Given this list of marker genes SKA2, LAT, SGO1, LINC02393 (long intergenic non-protein coding RNA 2393), IL9R, NR1I2, GUCA2B, SLC29A4, NFATC1, ATP5PB, CR2, TMEM231 (NCBI Gene Id 79583), CLHC1, VAX2, PAMR1, EI24, SLC2A2, ATP2A1, LRRC8C (NCBI Gene Id 84230), GAS7, LANCL3, MUC13, GP1BA, ATP1A3, ARAP2, KRT7, MSI1, DSPP, HOXA9, PRELID3A, TRIB1, NDUFAF6, THSD7A, RUNX2, GLS2, DNAJB13, SETD1B, NSD3, IL17RE, LIMK1, SNX18, MAP3K21, CYLC1 (NCBI Gene Id 1538), PDC, RAG2, GRAP, TNFRSF12A, IFNAR2, CTSZ, CASP7, FAM209A, MAD2L1, TBC1D32, SYNPO2L, BMP10, PANX3, SCLT1, CCDC157, MGAT4B, SLC10A6, TCHH, PRIM2, RABGGTA, WNT10A, MSANTD3, CPXM1, GLRA1, NPPC, ARHGEF39, RGS13, SPEN-AS1, LY96, LMO2, CFAP36, IGF2BP1, TMEM169, CEACAM20, MMP3, SHBG, ZNF784, ZNF334, KLHL32, SUCNR1, GNG8, CFAP43, TSNAXIP1, DPYSL3, P2RY10, MUC1, CENPS, TMEM138, PAK3, VEGFC, XBP1, SCNN1A, KRT8, HCN1, CEP89, ACER2, GYG1, SH2D1A, MZF1, KCNK12, DNMT3L, POM121, SUB1, TM6SF1, SFRP1, C16orf89, SLC2A3, CSTB, PLSCR4, CORO2B, LGALS12, TRPM2, TACSTD2, HBZ, KIAA0319, SIAE, SYNE3, CD28, ASB1, TSSK3, PPP6R2, NOSTRIN, GIPC2, CLIP4, APOA2, IL17RA, TTLL1, USP2, BBS5, TEX2, ERICH2, ICOS, SORT1, MCL1, CHRNA7 (cholinergic receptor nicotinic alpha 7 subunit), MAP9, GSTK1, PIP4P2, SP7 (Sp7 transcription factor), GSX2, TEAD3, RPL3, ROR2, CAMK2A (NCBI Gene Id 815), SLC6A18, CENPW, ARAP3, PGK2, MAOB, B3GALT5, FXYD5, TMCC3, CA13, RGS2, TECRL, HABP4, AUNIP, KLF3, NAPB, GALNS, C11orf24, NNAT, TMEM17, OR2C1, PITX2, PTPRE, IRF2BPL, LRRC56, NEGR1, SOHLH1, TRPC1, H1-0, DRP2, NR2C1, BMP2K, B3GNT5, TLR6, TGFB3, MAN1A1, PRKX, C18orf54, HECW2, GATA3, ARL10, ZNF608, CELA1, CENPB (centromere protein B), MYPOP, MYOZ2, PDE2A, DNAJB8, TLX3, MALL, ADCY1 (adenylate cyclase 1), CPEB4, GALNT6, FMO3, here is a description of the gene set: Human Gene Set: GSE24210_IL35_TREATED_VS_RESTING_TREG_UP species: Homo sapiens Genes up-regulated in T conv cells treated with IL35 versus resting T reg cells. Regulatory T cells (Tregs) play a critical role in the maintenance of immunological self-tolerance. Naïve human or murine T cell treatment with the inhibitory cytokine IL35 induces a regulatory population, termed iTR35, that mediates suppression via IL35, but not IL10 or TGFβ, neither express nor require Foxp3, are strongly suppressive in five in vivo models, and exhibit in vivo stability. Treg-mediated suppression induces iTR35 generation in an IL35- and IL10-dependent manner in vitro, and in inflammatory conditions in vivo in Trichuris-infected intestines and within the tumor microenvironment, where they appear to contribute to the regulatory milieu. iTR35 may constitute a key mediator of infectious tolerance and may contribute to Treg-mediated tumor progression, and ex vivo-generated iTR35 may possess therapeutic utility. from publication Collison LW, Chaturvedi V, Henderson AL, Giacomin PR, Guy C, Bankoti J, Finkelstein D, Forbes K, Workman CJ, Brown SA, Rehg JE, Jones ML, Ni HT, Artis D, Turk MJ, Vignali DA (PMID 20953201)